The following is a description of a gene set: Amino Acid conjugation Human Gene Set: REACTOME_AMINO_ACID_CONJUGATION studied in species Homo sapiens, and this is the list of marker genes: ACSM1, ACSM4, GLYATL1, GLYATL3, GLYATL2, ACSM2B, GLYAT, ACSM2A, ACSM5